The following is a description of a gene set: Bacterial infection pathways aim to capture molecular mechanisms of human bacterial diseases related to bacterial adhesion to and invasion of human host cells and tissues, toxigenicity (interaction of bacterially-produced toxins with the human host), and evasion of the host's immune defense.<br><br>Bacterial infection pathways currently include some metabolic processes mediated by intracellular Mycobacterium tuberculosis, the actions of clostridial, anthrax, and diphtheria toxins, and the entry of Listeria monocytogenes into human cells.<br><br>Clostridial toxins are produced by anaerobic spore-forming gram-positive bacilli of the genus Clostridium. Clostridium tetani causes tetanus, Clostridium botulinum causes botulism, Clostridium perfringens causes gas gangrene, and Clostridium difficile causes pseudomembranous colitis. The anthrax toxin is produced by the aerobic spore-forming gram-positive bacilli of the species Bacillus anthracis. The diphtheria toxin is produced by aerobic nonspore-forming gram-positive bacilli of the species Corynebacterium diphtheriae infected with the bacterial virus corynephage beta. Enterobacterial toxins are produced by pathogenic strains of Enterobacteriaceae, aerobic gram-negative bacilli that are part of normal intestinal flora, such as Escherichia coli.<br><br>Mycobacterium tuberculosis bacteria are acid-fast, aerobic, nonspore-forming bacilli that cause tuberculosis, a wide-spread disease that usually affects the lungs.<br><br>Listeria monocytogenes bacteria are aerobic nonspore-forming gram-positive bacilli that cause listeriosis. part of: Infectious disease Reactome Pathway: Bacterial Infection Pathways species: Homo sapiens, and this is the list of marker genes: STAM2, gspD2, fecC, SH3GL3, COL4A5, esxG, CBLL1, fepG, fepB, ANTXR2, AAC(6')-Ib, bcsQ, fepA, MAP2K1, eis, gspS2, tetX, mdtF, nleF, oppC, bcsG, PPE2, STX1B, eltB, bamB, sta1, hlyD, LAMB2 (NCBI Gene Id 3913), VAMP1, GUCY2C, VPS33B, ggtA, fhuD, CTNNB1, fecB, COL4A1, rpoB, secF, FURIN, iutA, CALM1 (NCBI Gene Id 801), feoB, COL4A3, ndkA, katG, fepC, RAB7A, MAP2K7, acrB, macB, rmtF, B2M, CASP4, fepD, HSP90AA1, mdtE, EPCAM, RAB5A, botB, fecA, inlB, adhE2, bcsA, yqjH, bamE, UBB, sapM, bamC, macA, mdtB, sta3, sta2, emrE, aldR, pef, botF, mdtC, eltA, HBA1, fhuC, armA, bcsC, feoA, KPNA1, botD, GBP4, exbD, dppF, pstS1, fes, csgA, NOS2, HBB, EEF2, dppC, PGK1, esxA, ahpD, fyuA, ybtP, GBP1, CD9, SH3KBP1, UBE2D2, Rv3655c, bamD, CDH1, fecE, SFPQ, draE, LAMA1, KPNB1 (karyopherin subunit beta 1), mdfA, SV2B, efeU, Rv1410c, hbp, qnr, znuC, fgd1, secA1, oqxA, yhjR, UBC, mrcB, LAMA3, LTF (lactotransferrin), exbB, ha70, cya, EPS15, GRB2, LAMA4, MAP2K6, entS, SV2A, znuA, chuA, secD, irtA, cpnT, COL4A6, sfaS, bfrB, tetA, lepB, znuB, UTI89_C2180, SRC, CTNND1 (NCBI Gene Id 82168), fkpA, GSK3A, HA-33, rmtD, GBP3 (NCBI Gene Id 55271), MT2748, ptpA, botE, STAM, dlaT, oppD, RNF213, skp, efeB, STX1A, trxA, COL4A4, ha17, acrA, espC, MAP2K2, UPK1A, ahpC, HBEGF, mppA, rpoC, rpoA, LAMC3, gdx, COL5A1, hlyE, TXNRD1, fecD, SYT1, oppB, NHERF4, LAMB3, secE, CALM2, gspC2, irtB, dppD, ipaH9.8, LAMC2, CBL, DUSP16, ahpE, efeO, rrsA, SH3GL1, lprG, MAPK1, MAP2K3, gyrB, LAMC1, dppB, rpoZ, VAMP2 (NCBI Gene Id 6844), Rv3364c, secY, rmtC, bcsB, botA, ntnha, trxB, CALM3, ospC3, dsbA, secG, SNAP25, RPS27A, degP, mrkD, pagA, COL5A2, bla, MET, HSP90AB1, UBA52, HGS, SYT2, acrD, ATP6V1H, GBP6, tpx, ANTXR1 (ANTXR cell adhesion molecule 1), LAMA5, TLR2, blaSHV-12, botG, sodB, msrA, dppA, hlyA, secA2, COL4A2, surA, bamA, MRC1, GBP2, SV2C, rmtG, secA, 16S rRNA, KPC-2, MAPK3, hlyB, fimH, PDCD6IP (programmed cell death 6 interacting protein), rmtB, rmtH, bcsE, papGI, Rv3654c, oppA, tonB, trx-2, lprM, MAP2K4, yqjI, sodC, TRIM27, SH3GL2, bfr, COL5A3, inlA, tolC, CTSG, glbN, lef, mdtA, esxH, gyrA, FN1, Rv2895c, lpdC, fhuB, ENO1, CORO1A, LAMB1, LAMA2, tetB